Given this list of marker genes SLC39A8, UPK3B, ID1, YPEL3, CYSTM1, WFDC2, CXCL1, HP, PRG4, KRT18, SLC40A1, KRT19, ADAMTS9, CLDN1, ADIRF, SLPI, TM4SF1, KRT8, GBP2, PROCR, MT1F, PDZK1IP1, PLA2G2A, MT1H, CFB, SAA2, IL13RA2, CALB2, CXCL6, SLC34A2, CEMIP, MT2A, CD74, SEL1L3, MT1G (metallothionein 1G), CHI3L1, PLAT, ID3, EGFL6, MGST1, MT1X, RARRES1, SELENOP, DAB2, MT1E, EZR, SAA1, UPK1B, TMEM176B, SERPINB4, here is a description of the gene set: In this study, an extensive analysis was conducted to define meta-programs (MPs) capturing intra-tumor heterogeneity across a spectrum of tumor types. The approach utilized non-negative matrix factorization (NMF) to analyze each cell type separately within individual tumor samples. This involved the analysis of malignant cells, macrophages, fibroblasts, endothelial cells, epithelial cells, T-cells, and B-cells. NMF was executed with varying parameter values (K=4, 5, 6, 7, 8, 9), thereby generating 39 programs for each cell type per sample. Each NMF program was summarized by the top genes based on NMF coefficients.\nRobust MPs were then delineated for each cell type using a set of stringent criteria, including recurrence within the same tumor, similarity to programs in other tumors, and non-redundancy within a tumor. Subsequently, these robust NMF programs were clustered (per cell type) based on Jaccard similarity, leading to the identification of MPs associated with each cell type.\nTo enhance the quality of the MPs, a refinement steps were undertaken, involving the removal of MPs suspected of reflecting low-quality data (with an overrepresentation of ribosomal proteins or mitochondrial-encoded genes), single-study inclusion, or similarity to miss-annotated cell types. Human Gene Set: GAVISH_3CA_METAPROGRAM_FIBROBLASTS_METAL_RESPONSE Genes upregulated in subsets of cells of a given type within various tumors from publication Gavish A, Tyler M, Greenwald AC, Hoefflin R, Simkin D, Tschernichovsky R, Galili Darnell N, Somech E, Barbolin C, Antman T, Kovarsky D, Barrett T, Gonzalez Castro LN, Halder D, Chanoch-Myers R, Laffy J, Mints M, Wider A, Tal R, Spitzer A, Hara T, Raitses-Gurevich M, Stossel C, Golan T, Tirosh A, Suvà ML, Puram SV, Tirosh I (PMID 37258682) studied in species Homo sapiens